Given this list of marker genes OAS1, SLC7A7, MARS1, CSF2RA, ABCA3, SFTPC, CSF2RB, ARPC5, SFTPB, HLA-DRB1, here is a description of the gene set: Intraalveolar phospholipid accumulation Accumulation of amorphous PAS-positive material in the space between alveolar macrophages, sometimes as condensed form (oval bodies) are typically found in alveolar proteinosis. Human Gene Set: HP_INTRAALVEOLAR_PHOSPHOLIPID_ACCUMULATION studied in species Homo sapiens